Given this list of marker genes TBC1D20, CLEC10A, LCMT1, GPR158, LINC00314, TRPC5OS, FAM53A, ITGA8, RAP1GDS1, MRPS18C, CD84, PMVK, COL28A1, RBFA, MRC1, SERPINB11, SNORD104, HSD17B10, ENSG00000230736, DTD2, NCKIPSD, UBE2G2 (NCBI Gene Id 7327), BIN2, WDR7 (NCBI Gene Id 23335), CHID1, TMX2, CNPY3, PIGL, NIBAN3, NDUFB2, CPN2 (carboxypeptidase N subunit 2), SLC2A1, POLE4, C11orf65, DDX56, OR52K3P, ABHD11, RNF227, GGT6, UBAP1L, DNMT1, TXNDC12, NBPF4, DDX51, FBP1, PLEKHA7, GPI, EXOSC4, TTC28, DMGDH, TPSD1, ZNF696, WDR64, ARMC12, NUP205, LINC00588, SOAT2, ULBP3, EIPR1, LINC01127, CCDC112, SNRPF (NCBI Gene Id 6636), TRAPPC2L, CPEB1-AS1, MAGEA1 (MAGE family member A1), MTOR, ZMYND8, SPO11, LSM6, FAM136A, S100A2, TMEM255B, SWSAP1, ACAD9, PHPT1, LINC02297, DPP3, COPS6, DFFA, SILC1, SYCE2, SLAMF8, FBXO9, ITGB2, SERF2 (NCBI Gene Id 88287), PGK1, SNX30, LPCAT3, RARB, CISD3, PI4KA, CCDC159, H2AC15, ADAP2, LINC00930, NXF1 (NCBI Gene Id 10482), CDKN2AIPNL, EIF4A3, RPS19BP1, TTLL13, PCOLCE2, POLR2H, DPY19L2P3, FUS, FOS, MFNG, CIPC, SLC12A2, PTGES2, KRT18, RPA2, MIR924HG, KCNK12, H3C8, EXOSC7, ERI3, XXYLT1, MRPS26, THOC6, RNF135 (ring finger protein 135), MPV17, RBPJ, RIOK2, DNAJC12, LRRC55, HEATR3, E2F7, GTF2A2, ATP5ME, LINC00842, INSL5, LINC00664, NME1, GNPNAT1, PAPSS1, PAK1, ATRIP, ANAPC7, ALDH1B1, GATD3, CEP20, C14orf119, BHLHE40, CLPP, LINC00589, NDUFA4 (NCBI Gene Id 4697), ASCC2, SCN11A, HDAC1, CEACAM6, KRTCAP3, LINC00937, SYT14, LYPLAL1 (NCBI Gene Id 127018), NRTN, GAPDH, CD1E, CLEC5A, PON2, TRUB2, PLPBP, MPLKIP, RNF152, CCSAP, COQ9, MRPS25, MDH2, NDUFS6, SKAP2, EVI2A, MCAT, MDN1, PDE6H, ANKDD1A, PTPMT1, WDR53, DISP1, SCD, KRT36, MACF1, TIMM8B, SNRNP40, ZBED5-AS1, CD9, NHP2, EID2, ATG16L1, MAN2B2, SDHA, PRDX4, KDM1A, CELF6, PLTP (phospholipid transfer protein, NCBI Gene Id 5360), POLE3, ALG1, here is a description of the gene set: Human Gene Set: GSE30971_2H_VS_4H_LPS_STIM_MACROPHAGE_WBP7_HET_UP from publication Austenaa L, Barozzi I, Chronowska A, Termanini A, Ostuni R, Prosperini E, Stewart AF, Testa G, Natoli G (PMID 22483804) studied in species Homo sapiens Genes up-regulated in bone marrow-derived macrophages with heterozygous MLL4 knockout: 2h LPS versus 4h LPS. Histone methyltransferases catalyze site-specific deposition of methyl groups, enabling recruitment of transcriptional regulators. In mammals, trimethylation of lysine 4 in histone H3, a modification localized at the transcription start sites of active genes, is catalyzed by six enzymes (SET1a and SET1b, MLL1–MLL4) whose specific functions are largely unknown. By using a genomic approach, we found that in macrophages, MLL4 (also known as Wbp7) was required for the expression of Pigp, an essential component of the GPI-GlcNAc transferase, the enzyme catalyzing the first step of glycosylphosphatidylinositol (GPI) anchor synthesis. Impaired Pigp expression in Wbp7-/- macrophages abolished GPI anchor-dependent loading of proteins on the cell membrane. Consistently, loss of GPI-anchored CD14, the coreceptor for lipopolysaccharide (LPS) and other bacterial molecules, markedly attenuated LPS-triggered intracellular signals and gene expression changes. These data link a histone-modifying enzyme to a biosynthetic pathway and indicate a specialized biological role for Wbp7 in macrophage function and antimicrobial response.